The following is a description of a gene set: Any process that modulates the frequency, rate or extent of a response to stress. Response to stress is a change in state or activity of a cell or an organism (in terms of movement, secretion, enzyme production, gene expression, etc.) as a result of a disturbance in organismal or cellular homeostasis, usually, but not necessarily, exogenous (e.g. temperature, humidity, ionizing radiation). studied in species Homo sapiens Human Gene Set: GOBP_REGULATION_OF_RESPONSE_TO_STRESS, and this is the list of marker genes: GRP, CD160, STAT3 (NCBI Gene Id 6774), CD37, ING3, POLR3G, PCNA (NCBI Gene Id 5111), GPR31, CASK, APOBEC3F, ATP2B4, RMI2, HERPUD1, ALPK1, LRRK2, TRIM62, YY1, SKP2, SETD2, LRFN5, HDAC10, IL12RB1, FOXA2, KANK1, MIR200C, CFH (complement factor H), CNOT7, PYHIN1, FBLN5, HCFC2, ADTRP, TOP2B, PTGIS, KLHL15, SEMA4C, TTBK1, MIR4286, PARP14 (poly(ADP-ribose) polymerase family member 14), RACK1, TAF5L, BCL7A, TXK, MIR195, PLA2G5, INPP5F, COPS3, PIK3R6, ATXN7L3, MMRN1, HSPA5, MAGEF1, KCNK2, IL22RA1 (interleukin 22 receptor subunit alpha 1), KIAA0319, RTEL1, UIMC1, C1QTNF3, SLAMF6, RPL26, STAT1, IL20, PAK2, RBX1, RAD52, SUPT7L, LGALS9, MYLK (NCBI Gene Id 50483), FLOT1 (flotillin 1), ELP6, MARCHF7, NLRP10, PPP1R10, BCL6B, NT5E, MIR26B, DDX41, GHRL, SPIDR, KIR2DL4, GPR108, RAD9A, CRHBP, NEO1, RAD50, DHX33, IL27, AHR, CD200, CMA1, OASL, ZDHHC5, TNR, FGF2, MICB, DUOXA2, PDPK1, AGER, UNC93B1, INO80B, PAK3, LACC1, TNFSF11, CXCL6, PLCG1 (phospholipase C gamma 1), PDE2A, NUPR1, PARK7, CLOCK, GDI1, F2, CADM1, EFHD1, TSLP, PDGFB, SLC15A4, NAPEPLD, IRAK2, DUSP10, DRD2, TEX15, LILRB1, SAMHD1, TADA1, MIR19B1, ERCC1, AKT2, FLOT2, SLC19A1, MACIR, MTOR (mechanistic target of rapamycin kinase), PPARA, BBC3, CD96, DDX3X, TRIM15, MEAF6, SOX4, SMARCC2, TAF9, FYN, C3, TNIP3, PQBP1, CTSC, CD28, OTOP1, SMAD3, TLR3, MMP12, CLEC6A, YWHAZ, MIR204, TTLL12, EXTL3, IL2RA, DNAJB9, NCK1, MDM2, SELENOS, MIR187 (NCBI Gene Id 406963), SPRING1, MAPK1, BCL6, FERMT1, CLEC4E, DMTN, KLRK1, MBL2, BCL2L12, RPS3, SPI1, DAGLA, WDFY1, C2CD4B, KLRB1, SUPT20H, IDO1, PAK1, TNFRSF1B, RPS6KA3, EIF4G1, GBP3, CALHM6, SHARPIN, SETMAR, EPO, MACROH2A1, RNF170, NFRKB, CEBPG, IL20RB, AOAH, NLRP14, LYAR, ZBP1, BRD4, APPL1, ZCCHC3, MAPK3, PTPRS, BDKRB2, SETD4, ACE2, WDR48, TXNDC12, MIR205, TNIP2, ZMPSTE24 (zinc metallopeptidase STE24), PPP1R15A, CREB3L1, NFKBIL1, IL17RA, F11, TICAM1, TKFC, PARP9, FBXO4, FOXP3 (forkhead box P3), AKT3, ACTL6A (NCBI Gene Id 9178), NLRX1, IRF4, NLRP2, NR1H4, PPP1R13L, UCN, OAS3, IRF3, BANF1, WRAP53, SGF29, FBXL2, GPS2, SERPINB9, CYREN, KIR2DS2, DHFRP1, INAVA, SPINK5, HYOU1, GGT1, BCL7C, PARP3, VTN, CHCHD2, SGTA, NAGK, OGT, TLR6, IL16, HELQ, MMP8, BCL7B, BST1 (bone marrow stromal cell antigen 1), PRRX1, DROSHA, GHSR, PTGES, TTI2, PROS1, SF3B5, PGC, GPR17, C1QBP (NCBI Gene Id 708), RB1, PDCD4, MEF2C, FERMT2, COPS5, IFI35, ANXA1, YBX3, AP3B1, RNF168, IFNK, UBE2V1, FCN3, ABL1, DDRGK1, KLRC1, NEK7, EP300, NLRP4, AIFM2, SHPK, FGG, TP53, KEAP1, CLNK, PRKAR1B, PHB2, F12, MIR200B, VPS35, SHLD1, MFHAS1, STK25, POLR3C, ZP3, FIGNL1, TSPAN6, S100A14, IL1RL1, MIR222, SIRT6, BCL2L1, ERRFI1, MIR105-1, FGR, TMX1, SMCHD1, CR1, AP1G1, CCL5, TAF9B, ALOX15 (NCBI Gene Id 246), MIR31, SH2B3, CD74, LTF, HLA-E, MIR766, MAP2K1, PSMB4, F2R, EPC1, PPARG, TYRO3, BABAM2, IL13, HAVCR2, IL18RAP, CCR7, LEP, BRCA1, MCPH1, DNAJC2, ADA, PSMA1, AXIN2, MGLL, MYC, MAPK14, GGT3P, CASP1, TAOK2, CCDC134, TNF, MATR3, RNF216, ZC3HAV1, NFKBIA, NECTIN4, BABAM1, APOH, GREM1, CALHM2, RAB7B, TRAF3IP3, OGG1, TNIP1, KLK5, DDX5, NPAS2, TNFAIP3, NLRC4, TBXA2R, VEGFB, CD200R1, C1QTNF1, BCL2, MIR181A2, TMEM126A, DNASE1, ARID1B, MIR488, LRRC19, CDK9, PIGBOS1, IGBP1, MIR708, AGR2, MSX1, RAG1, BRAF, TIFA, RIOX1 (NCBI Gene Id 79697), DDIT3, MIR3909, ATF6B, SUV39H1, RNF135, LY96, SBNO1, RIPK2, SARM1, ACTR8, APP, PLA2G7, FAM168A, CASP6, TLR8, ATXN7, INO80D, FXR1, RNF125, NACC2, LRIG2, SESN3 (sestrin 3), RGMA, LAMP2, KLK7, TOMM70, DEFB114, SELE, SOCS5, IL6, IRAK4, GRN, VIL1, LILRA5, MAPK8, SCIMP, KAT2B, RAET1E, TTI1, TRIM11, ABCA7, CCDC117, CDH5, TADA3, MID1, KNG1, RORA, TMEM161A, PF4, IL37, CCAR2, CD200R1L, NLRC3, LGR4, C11orf54, MIR146A, CASP5, SPSB3, TLR5, STAT5A, TRAF3IP1, APOE, HERC5, AKNA, MIR141, NLRC5, TNFSF18, PHB1, WFS1, DTX4, PPP4R3B, MUL1, MAD2L2, GGT7, CBX8, XRCC5, HIC1, DYRK1A, ERBIN, MAPKAPK3, CD300LF, TELO2, EYA4, RASGRP4, USP51, IL17RB, HSPA8, SPP1, ABRAXAS1, TAF2, GBP1, NLRP7, FBH1, KMT5B (NCBI Gene Id 54794), ERP29, USF1, RTN4RL1, ENPP4, ETS1 (NCBI Gene Id 2113), PBRM1, YJU2, CD109, EPHA4, TMSB4X, ACTR2, HTR2A, FUS (FUS RNA binding protein), C1QTNF12, MNDA, DDX11, SPIRE2, ELL3, PTGER3, AARS2, FCN2, CREBRF, S100A9, TRAF6, HSPD1, PMAIP1, NBN, TIMELESS, DAGLB, ROCK2, HSP90AA1 (NCBI Gene Id 89272), LILRA2, MVK, FUT7, PRMT1 (protein arginine methyltransferase 1), DYRK3, USP18, CD47, SVIP, TBK1, PLA2R1, GRAMD4, TRIM45, ADCY8, UBQLN2, MIR206, GPER1, GRINA, PLA2G10, DNAJB1, KCNJ8, ALOX5, LAMP1, ELMOD2, FADS2, NOL3, MAPT, PLA2G2A, KLRD1, XBP1, TREML4, KLF4, XIAP, STAT2, PNPLA8, ANXA2, PAQR3, IL18, PYDC1 (pyrin domain containing 1), IKBKB, LBP, FAP, HDAC6, KLKB1, IGFBP6, PML, TLR9, DDR2, TNFSF4, LPL, MIF, GPATCH3, TAC1, PPP3CA, CELF1, MIR22, RABGEF1, F7, PTPN11, WASHC4, ISL1, USP27X, SPHK1, FOXO1, FEM1A, DUOXA1, MAPKAPK2, MIR34B, ABHD17A, DDX39A, CREB3L3, FMN2, POLR3F (RNA polymerase III subunit F), CD300C, TAFA5, CRTAM, FANCB, CLPB, MRNIP, SOCS3, PPARD, IKBKE, ATAD5, SPATA2, PVR, DTX3L, MLC1, EP400, FAS, SESN1, GFI1, TASL, MIR17, COLEC12, SBNO2, NDFIP1, MIR26A1, VHL (NCBI Gene Id 8056), EIF4E2, NLRP11, ECSIT, APCS, CCL24, DDX60, EDN1, DPF3, HYAL2, PLAT, A2M, SPIRE1, THY1, HTN3, MEFV, ITGB1, PSMA6, TAX1BP1, HRG, EYA3, ARG2, RFTN1, PHF10, HSPA1B, FNDC4, FADD, STK39, MLIP, RAET1G, MIR25, BRCA2, DUOX2, CX3CL1, PTEN, SETD7, NFE2L1, RECQL5, APPL2, SAA1, KLRC3, NCR1, ATG12, BIRC3, BPIFB1, NFE2L2, WNT5A, NECTIN2, CXCL12, GBP5, BAG6, LSM14A, ENY2, PLG, OTULIN, POLR3B, RIOK3, KMT5A, PIK3CB, MMP14 (NCBI Gene Id 4323), C2CD4A, BCR, CREB3, TAF6L, COMMD1, AMFR, BTK, DDIAS (NCBI Gene Id 84145), TARBP2, IL10RA, FCGR1A, SUPT3H, HMGA2, ATAT1, ABCC1, CSNK2A1, IPO5, SIGLEC10, SFN (stratifin), EPPK1, TLR1, ZDHHC9, NLRP12, MIR132 (microRNA 132), DNASE1L3, EIF2AK4, SPRED2, MIR208A, PLA2G3, ZDHHC4, GGT2P, EMILIN1, ADAMTS12, UCHL5, RTN4 (NCBI Gene Id 57142), MIR96, NOP53, SESN2, SERPINE2, CASP4, TSPAN32 (NCBI Gene Id 10077), CGAS, FGB, BAK1, POLR3D, NLRP2B, ATF6, PLA2G2D, TNC, PPP2CA, IL10 (interleukin 10, NCBI Gene Id 3586), ERCC6, MTCH2, ACKR3, AKIRIN2, CLDN3, TRRAP, TAF4, LAG3, IL15, EGLN1, KREMEN1, YES1, TNFAIP8L2, IL23R, METRNL, GPR4, IER3, PTPN2, IKBKG, MCTP1, FICD, NCR3, ESR1, ABHD8, GP1BA, BID, DUOX1, IFNLR1, IL1RL2, ADAMTS18, SCARF1, MIR126, ZNRF4, ENO1, SHLD3, POT1, SMARCA4, MIR520B, AGT, MAVS, MAP3K7, SMARCA2, KARS1, GPSM3, APOA1, SMIM30, RNF185, INS, GRB2, FFAR4, PJA2, MGMT, PGLYRP2, AGTR1, OCLN, NT5C2, DSG2, ACTR5, SLC25A23, AHSG, TP53BP1, CREBBP, NFKB1, TRPC3, PIK3R1, TAB1, MAPKBP1, CYP19A1, AJAP1, LRP8, SENP3, CEBPB, MICA, GBA1 (NCBI Gene Id 82008), TICAM2, STK19, HLA-F, OPA1, MIR144, IL17A, XRCC1, SLAMF8, DDAH1, GPX1, USP13, ZCWPW1, SHLD2 (shieldin complex subunit 2), CCL3, SNX6, CPB2, FABP4, FOXC2, MIR19A, MDK, TLR4, MAP3K8, MIR520E, ISG15, OPRM1, MRE11, SMARCE1, PPP4R3A, JAK2, LRCH4, CRY1, GSDMD, PARPBP, SLC25A14, STING1, INO80C, TLR7, ING2, GCH1, PRKDC, PTPN1, VAMP2, ANO6, NLRP6, PDGFA, GSK3B, OAS1, TBC1D24, PRKD1, FOSL1, RNF144A, BCL2L11, DNAJC7, SERPINB2, TIGAR, MIR214, DMAP1, USP50, FOXP1, IL2, MRGBP, MIR34C, ENPP3, TREM2, REG3G, AKT1, SNX4, ADORA2B, DHFR, HSP90B1, MARCHF6-DT, MCRS1, STAT5B, KAT5, S100A8, OTUB1, PDX1, SERPINB4, TEK, TAOK1, BFAR, SOD1, SNAI2, ERCC4, PLK2, RASGRP1, EREG, WAS (WASP actin nucleation promoting factor), SMPDL3B, MIR15A, ARNT, COLEC11, CD44, NLRP13, TP73, FGA, IFI16, HPX, CD14, IFNG, FCER1G, CDKN2D, DNMT3A, RPS19, TRIM25, ABCD1, ALOX12, YWHAE (tyrosine 3-monooxygenase/tryptophan 5-monooxygenase activation protein epsilon), MIR302E, TRPV4, NLRP1, IL33, RAD51, RIGI, NSD2, PPP1R15B, RELA, PARG, PARP1, HPSE, GIT1, ARFGEF1, USP14, UACA, LETM1, CD36, USP38, DAB2IP, TAF10, TSPAN8, PTPN22, TIRAP, SLF1, NPY, SMPDL3A, S100A12, RNF31, FEM1B, SFRP2, VSIG4, ADAM8, PIAS4, TNFAIP6, CYBA, MED1, ATAD3A, OSM, ETAA1, MIR451A, ACACB, MMRN2, MIR92A1, MIR181C, SIRT7, ACTG1, MORF4L1 (NCBI Gene Id 10933), CLEC12A, FGL2, WNT4, SH2D1B, MBTPS2, UBXN1 (UBX domain protein 1), MAP2K2, EPHB2, PPIA, ADCYAP1R1, HLA-DRB1, CRH, RSAD2, CLASP2, RAB11FIP2, NOS3, KLRC4-KLRK1, CARD9, VAV1, FFAR3, CYLD, SRC, PINK1, RTCA, ACOD1, SKIL, SLC38A2, MIR431, HNRNPK, SH2D1A, EMILIN2, PPP4R2, NPY5R, GKN2, UBE2V2, SF3B3, DNAJA3, THBD, KRT1, LRRC14, IL22, PTK2, OOEP, SLC46A2, IRF1, CCDC92, ZNFX1, IFIH1, SIGLEC16, CERS2, ATG5, SPN, MIR20A, GRPR, UBQLN1, CACTIN, GATA3, LPCAT3, GBP2, DPF2, TADA2B, IL6ST, EPG5, CARD8, MAPK7, NKG7, CTSS, HRAS, MIR142, SRSF6, DCST1, MIR128-1, MIR149, AIM2, MKRN2, MIR21, MIR30C2, TAFA3, MGST2, DPF1, CPT1A, ARRB2, SIRT1, GSTP1, MAPK13, CHUK, PAGE4, TNFRSF12A, RIPK1, INSIG2, PDGFRA, UBXN2A, LDLR, NAGLU, SYK, SELENOK, RICTOR, UFL1, SERPING1, BARD1, DNAJA1, CCN3, BRCC3, F3, ANKRD1, NR5A2, TAF7, USP25, FAM76B, UBQLN4, TGFB1, CD300E, SMARCD1, N4BP1, USP1, ELF4, OSMR, MIR145, TAF12, CD300A, NR1H3, IL12A, CCR2, EIF2AK3, PLAUR, PELI1 (NCBI Gene Id 57334), MICU1 (mitochondrial calcium uptake 1), RNF115, ZNRF1, MIR6869, ERAP1 (endoplasmic reticulum aminopeptidase 1), XCL1, PTTG1IP, OXR1, TRIL, ATM, ZDHHC11, PLCG2, PYDC2, PUM2, TMED2, ADRA2A (adrenoceptor alpha 2A), SMYD2, IL26, PYDC5, PRKCE, IL12B, SEC14L1, CDC37, IRAK3, CLDN4, CADM4, UBASH3B, EVPL, LYN, TMBIM6, IRF5, CNTF, RNASEH2B, USP19, NOD1, BECN1, SELENON, RNF26, TRADD, TWIST1, AREL1, HELB, TRIM41, PTGS2, FUT8, CST7, TRAF3IP2, ADAM17, PYCARD, LGALS2, TRIM21, HLA-G, NLRP9, TRIM44, TRIM5, MEAK7, FCRL3, CRK (NCBI Gene Id 1398), VPS72, MIR590, TRIM6, FBXW7, HGF, MIR199A1, ST3GAL4, SIN3A, USP22, RTN4R, SPRED1, HLA-A, CASP8, INSL3 (NCBI Gene Id 6020), MAGEA3, TRIM28, ZDHHC3, MIR1298, CCL1, RHBDF2, SIRT2, CLEC7A, LETMD1, IFNB1, MIR920 (microRNA 920), PRDX2, PRKCD, ELANE, RHBDD3, ZC3H12A, TLR10, IRAK1, REG3A, NLRP3, MMP9, LATS1, DEK, MIR657, FAM3A (FAM3 metabolism regulating signaling molecule A), RADX, VAMP7, UFD1 (NCBI Gene Id 7353), BMP7, ARMH4, RIF1, PRDX1, IL17F, LATS2, PRKN, PTPRC, SERINC3, P2RX7, NFKBIZ, KLRC2, MIR221, CLASP1, SETD6, BRD8, FPR2, IRF7, RNFT1, CEACAM1, SQSTM1, MIR140, SCARA3, TIGIT, RBM14, SMARCB1, PPP4C, HSF1, PLAU, ABHD12, IL1R1, CEP63, PIK3AP1, NMI, ARL6IP5, EPC2, SFPQ, RNFT2, FFAR2, KCNK13, LTA, ACP5, TLR2, PPP6C, HSPA1A, TMEM97, IL21 (NCBI Gene Id 59067), RUVBL1, QARS1, HDGFL2, MAPK8IP2, MIR29A, SLC15A3, SMARCD2, NTRK3, MAS1, NONO, WFDC1, TRIM32, INO80E, RNF8, CASP3, GPRC5B, LILRA4, ERN1, RFWD3 (ring finger and WD repeat domain 3), RAD51AP1, MAP2K6, KCNK6, IL23A, TFPI, MIR138-1 (NCBI Gene Id 406929), MIR210, RPA2, BCAP31 (B cell receptor associated protein 31), IL4 (interleukin 4), NEAT1, ZBTB7B, PPT1, EYA2, ERCC8, CAV1, CLEC12B, PHLDB2, MIR34A, EGFR, THBS1, KDM1A, TRAFD1, TRIM22, TMEM33, NPM1, CHEK2, SNAI1, NLRP5, STMP1, FOXM1, SERPINC1, GATA6, NINJ1, IER5, HMGB2, RREB1, POLQ (NCBI Gene Id 29043), SLC7A11, CD300H (NCBI Gene Id 100130520), PDCD10, XRCC6 (X-ray repair cross complementing 6), NOD2, MBTD1, KMT5C, YTHDF3, EDNRB, ARID2, CSNK1A1, POMC, TNFRSF11A, STK24, PPM1B, POLH, ZNF385A, PSPC1, NR1D2, ANKRD17, PTN, RNF126, ATRIP, FIGNL2, CCN4, PSMD10, SERPINE1, KLK3, IL1B, METTL3, PLSCR1, CLDN1, HAPSTR1, SYVN1, KDM4D, IL22RA2, GNAS, BMP10, ACTB, DHX58, SLF2, APOBEC3G, APLNR, ILRUN, RNF169, MIR16-1, CUL4A, ATXN3, MARK4, PGLYRP1, USP29, HBEGF, EYA1, IGF1, AQP11, FH, TRIM65, TRIM3 (NCBI Gene Id 10612), DHX9, IRGM, DNAJB6, CAMK2N1, LRSAM1 (NCBI Gene Id 90678), MIR4691, KHDC3L, TAF5, ATXN3L, ING4, USP47, ADAR, NLRP8, F2RL1, TRAF3 (TNF receptor associated factor 3), MUC1, NCF1, NCK2, TRIM56, ZDHHC18, CD274, TMEM259 (transmembrane protein 259), CD226, TERF2IP, TRIM31, TRIM38, TGFB2, SMOC2, PENK, INO80, EEF1E1, NR1H2, PIM1, CD9, KLHDC10, RNF34, MORF4L2, KAT7, BCL10, UBE2N, FANCD2, PRKCG, INSIG1 (NCBI Gene Id 3638), VAMP3, STUB1, TFIP11, CLN3 (CLN3 lysosomal/endosomal transmembrane protein, battenin), KAT2A, AJUBA, YEATS4, PPP4R3C, STAP1, DDT, YTHDF2, USP15, FCGR2B, UBE2K, GIGYF2, COLEC10, SIRPA, PLK1, SLC12A2, TAOK3, ARHGEF2, NPLOC4, MMP3, CXCL17, MMP26, ADIPOQ, CLU, FOXF1, SUCNR1, ARG1, SMARCD3, PIK3CG, SERPINF2, LYPLAL1, PPP2R3C, CHORDC1 (cysteine and histidine rich domain containing 1, NCBI Gene Id 26973), RNF39, FGF10, H2AX, ADORA1, BRD7, HTN1, BAX, NUDT16L1, SEMA7A, TPT1, SNCA, MAPKAP1, RBM47, FCN1, TAF6, PBK, ADORA2A, BIRC2, PTPN6, HEXIM1, OTUD4, NCOA7, CD1D, CEBPA, TFPT, ATR (NCBI Gene Id 57307), PTGER4, HLA-B, SYT11, AURKB, SCGB1A1, MIR223, OPTN, MIR15B, PNKP, USP17L2, TIFAB, CORO2B (NCBI Gene Id 10391), MIRLET7G, FANCA, WDR76, MIR181B1, RUVBL2, SLC39A8, PTPRF, CHEK1 (NCBI Gene Id 1111), MARCHF5, CASP12, AUNIP, TERF2, PROC, CPTP, CD81, ZNF365, STOX1, MANF, NAIP (NCBI Gene Id 82693), KLRC4, SLC15A2, MYD88, BOK, FURIN, ASH1L, ZNHIT1, TNFRSF1A, MYOZ1, INPP5D, SMARCC1, BAD, MIR361, TRIAP1, HCK, PCBP2, LGALS1, ITCH, PUM1, ACTL6B, MAP3K20, NR1D1, PRKG1, BAP1, HMGB1, RNF183, EIF2AK2, VAMP8, ZDHHC12, CDKN2A, TYROBP, SUSD4, ARID1A, LMNA, TREX1, ZDHHC1, NBR1